The following is a description of a gene set: BH3-only proteins associate with and inactivate anti-apoptotic BCL-2 members Human Gene Set: REACTOME_BH3_ONLY_PROTEINS_ASSOCIATE_WITH_AND_INACTIVATE_ANTI_APOPTOTIC_BCL_2_MEMBERS studied in species Homo sapiens, and this is the list of marker genes: BCL2L1, PMAIP1 (phorbol-12-myristate-13-acetate-induced protein 1), BBC3, BCL2L11, BCL2, BAD, BMF, STAT3, BID